The following is a description of a gene set: species: Homo sapiens Human Gene Set: PID_PI3K_PLC_TRK_PATHWAY from publication Schaefer CF, Anthony K, Krupa S, Buchoff J, Day M, Hannay T, Buetow KH (PMID 18832364) Trk receptor signaling mediated by PI3K and PLC-gamma, and this is the list of marker genes: STAT5A, KRAS, NGF, FOXO3, AGAP2, CCND1, YWHAG, YWHAQ, PIK3CA, YWHAZ, GRB2, EGR1, SRC, NRAS, PRKCD, YWHAB, GSK3B, CAMK4, TRPC3 (NCBI Gene Id 7222), PLCG1, TRPV1, YWHAE, PDPK1 (3-phosphoinositide dependent protein kinase 1), CREB1, AKT1, BAD, PIK3R1, GAB1, HRAS, EPB41L1, CAMK2A, SOS1, SHC1, SFN, YWHAH, NTRK1